Given this list of marker genes IGFBP5, FOXO1, NOL3, ERRFI1, APLNR, PPARG, NOS3, SMAD3, KLF4, MIR214, ATP2B4, LMNA, MLIP, MIR25, here is a description of the gene set: Human Gene Set: GOBP_NEGATIVE_REGULATION_OF_MUSCLE_ADAPTATION Any process that stops, prevents, or reduces the frequency, rate, or extent of muscle adaptation. species: Homo sapiens